Given this list of marker genes IGFBP3, NAV2, DHRS3, DLC1, RARRES1, PDGFRA, SNX8, IGFBP6, ZNF133, RARB, KIT (KIT proto-oncogene, receptor tyrosine kinase), GDE1, COTL1, PLAUR, ITGA1, AKAP12, SMAD3 (SMAD family member 3), CAPN7, ETV1, CLDN11, TAL1, KANSL3, LRRC32, here is a description of the gene set: from publication Zirn B, Samans B, Spangenberg C, Graf N, Eilers M, Gessler M (PMID 15897880) Genes up-regulated in MZ128 cells (Wilms tumor with mutated WT1) after treatment with 10 microM tretinoin (ATRA) for 24 h. Wilms tumor is one of the most frequent neoplasias in children. Our previous microarray screening in a large series of Wilms tumors revealed several candidate genes that are deregulated in advanced tumors and are part of the retinoic acid signaling pathway. To investigate whether retinoic acid could be employed as a novel therapeutic agent in these tumors, we treated cultured Wilms tumor cells with different concentrations of all-trans retinoic acid (ATRA) and assessed gene expression changes by real-time RT-PCR as well as microarray analysis. Several genes like RARRES1, RARRES3, CTGF, CKS2, CCNA2, IGFBP3, UBE2C, CCL2 or ITM2B that were previously found to be deregulated in advanced tumors exhibited opposite expression changes after ATRA treatment. In addition to enhanced retinoid signaling, the transforming growth factor-beta (TGFbeta) pathway was strongly activated by ATRA treatment of Wilms tumor cells. Both the retinoic acid and the TGFbeta pathway mediate inhibition of cell growth. These findings represent the first molecular evidence of a potential benefit from ATRA treatment in Wilms tumors. Human Gene Set: ZIRN_TRETINOIN_RESPONSE_WT1_UP species: Homo sapiens